Given this list of marker genes Gls2, Asnsd1, Bhmt2, Noxred1, Mri1, Otc, Psph, Hao1, Gls, Mtr, Mthfr, Got2, Tha1, Cln3, Bcat1, Pcbd2, Plod2, Bcat2, Bhmt, Aasdhppt, Lgsn, Pycr3, Mthfd1, Agxt, Apip, Pcbd1, Agxt2, Shmt2, Phgdh, Thnsl2, Oat, Ilvbl (ilvB (bacterial acetolactate synthase)-like), Mtrr, Asl, Pah, Asns, Nags, Shmt1, Pycr1, Adi1, Aldh18a1, Bhmt1b, Mtap, Mthfd2l, Psat1, Pycr2, Slc25a12, Enoph1, Aass, Got1l1, Glul, Ass1, Got1, Plod3, here is a description of the gene set: The chemical reactions and pathways resulting in the formation of any amino acid that is incorporated into protein naturally by ribosomal translation of mRNA, and that has a specific codon for translation from mRNA to protein. Mouse Gene Set: GOBP_PROTEINOGENIC_AMINO_ACID_BIOSYNTHETIC_PROCESS species: Mus musculus